Given this list of marker genes SDCBP, BRAP, CALHM6, TRAFD1, CALN1, XAF1, PPP4R1, IRF7, KRAS, DOCK10, NEK9, SP2, IQGAP1, SLC2A8, TMEM87A, ZEB1, BRD2, GBP5, PRPF40B, FLI1, TET2, PARP14, GPR146, BTBD19, EPN1, NFATC3, SIKE1, MIR325, UBR2, ZPBP2, GPR132, RARG, PICALM, TRAPPC2L, MIR211, KBTBD3, E2F6, YJU2B, MTMR3 (myotubularin related protein 3), MAPK14, TRAPPC2, SLFN5, ITGA6, WARS1, RFFL, NCOA3 (NCBI Gene Id 8202), KAT2A, ARL2BP, SLC31A2, AKAP10, AZI2, NXPE3, AXIN2, FBXW10, NEK3, AMDHD2, MAF, AHR (NCBI Gene Id 196), CCL4, GDF2, POLR3B, FCHSD2, SP1, PBRM1, MPHOSPH9, RAB33B, PNPLA2, MSI2, L1CAM, ICOSLG, TBC1D23, PDE11A, RCOR1, MIF4GD, SYS1, CLINT1, ABHD16A, TGFBR1, TGIF1, HTATIP2, CLDN23, CD47, SMUG1, HECTD3 (NCBI Gene Id 79654), IFNGR1, GZMM, TMEFF1, TSPO (translocator protein), SFT2D2, XPR1, EXOC1, SGCB, GSTT1, JARID2, SLC48A1, RNF6, ATG2A, DVL3, STRBP, TMED4, JAK2, TNFAIP3, ENTPD6, ANGEL2, WEE2, RRAGD, GBP2, KIDINS220, MBTD1, CD200R1, DCAF4, FKBP15, NQO1, ZMYND12, PRKAB2, BARX2, NFE2L2, ARRDC2, LMBRD1, KHDRBS1, NIN, CACNB1, UBL3, FBXO28, SNX15, GVINP1, PLK3 (NCBI Gene Id 1263), ARL15, ZC3H7A, DNAJC7, STAT2, TNKS, IRS2, AP3D1, SMAD2, IFNGR2, N4BP1, IFIT3, CRLF3, ATP11B, C1GALT1, MLYCD, SOCS1, TRAT1, MOSMO, RNF31, CRK, DAPP1, TAPBP, RPS6KA5, TAF1A, IL7R, SYDE1, PCDHB10, ARIH2, SEC16A, CSNK1G2, PGM2L1, MIRLET7D, LYST, here is a description of the gene set: Human Gene Set: GSE15624_CTRL_VS_3H_HALOFUGINONE_TREATED_CD4_TCELL_UP from publication Sundrud MS, Koralov SB, Feuerer M, Calado DP, Kozhaya AE, Rhule-Smith A, Lefebvre RE, Unutmaz D, Mazitschek R, Waldner H, Whitman M, Keller T, Rao A (PMID 19498172) T cell differentiation to the Th17 effector subset requires stimulation through the T cell and co-stimulatory receptors, together with cytokine stimulation by TGFb and IL-6. The small molecule halofuginone (HF) inhibits Th17 cell development and induces a pattern of stress-regulated gene expression that mimics amino acid starvation. We used global transcript profiling to ask how halofuginone modulates gene expression induced during T cell activaiton and Th17 differentiation studied in species Homo sapiens Genes up-regulated in CD4 T cells: control versus treated with halofuginone for 3h.